Given this list of marker genes ATP9A, MDM2, ERGIC3, PRP4K, MX2, DYNLT2B, PKIG, ICE1, CHP1, VAMP2, RAN, SLC35D3, PTPN23, NUP214, CHP2, COMMD1, UBE2J1, INSIG1, WNK1, KHDRBS1, SIRT6, MLC1, EPM2A, TRIM46, CHRM1, STX18, RBM22, PIK3R2, VPS35, RUFY3, MYBPC3, CHMP3, CPSF6, IFNG, PLA2G3, ERLEC1, MAPK3, PCSK9 (proprotein convertase subtilisin/kexin type 9), NF1, TM9SF4, PPM1A, GRIPAP1, OAZ2, RAB21, SEPTIN8, KIF20B, EIPR1, PRR5L, FLNA, NF2, ANXA2, BVES, GLI3, TMEM97, PTPN1, RAB11A (NCBI Gene Id 8766), RBM4, WWC1, OAZ1, HSP90AA1, ARHGAP1, SHH, TTC21B (tetratricopeptide repeat domain 21B), CRYZL2P-SEC16B, IFI27, RANGAP1, MTMR4, SLC51B, SH3TC2, REEP2, GAS6, ARV1 (NCBI Gene Id 64801), NEAT1, ZDHHC2, EI24, CAMK1, RIOK2, MDFIC, CABP1, RAB29, FERMT1, DAB2, JUP, TRIM58 (NCBI Gene Id 25893), MAP2K1, ANGPT1, MAVS, CDH1, NUMA1, TRIM28, EP300, SIRT7, CRYAB, FRAT1, TPR, PIK3R1, REEP6, SFN, PLN, NUP58, ADIPOQ, UBE2G2, INPP5F, GCC2, PLA2G4E, TXN, EDEM2, UFM1, PSEN1, ARHGAP44, UHMK1, MSN, BORCS5, HHEX, STRIT1, NFKBIA, PRKACA, CDK5, DYNC1H1, NEFH, NDRG4, PRKN, GAS1, BMP4, RAB11FIP3, SCFD1, YOD1, AAAS, EZR, ABCA2, MAP1B, BCAP31, MTMR2, SNX12, LEP, PTPN11, ARHGAP8, REEP5, DNAJC13, SPAG5, ABCA12, HYAL2, UBR5, DDX39A, BRSK2, IER3, EDEM1, DENND10, RAB23, MIR27B, GSK3B, SNX3, PLK3, ECT2, XPO4, PCM1, CDK1, RNF139, RAB11B, RUFY4, CAPN10, SMAD3, YWHAB, OS9, THOC2, MIR185, NUS1, PGAP1, ATP2A1, CTDSPL2, UBAC2, SRC, PARK7, STK11, LRRK2, DERL2, HAP1, SMO, SUFU, LDLRAP1, EFCAB7, MYLK2, PRKCD, HDAC3, SCP2, DHX9, ALKBH5, SUMO1, FRAT2, IWS1, CD81, MAP2, JAK2, PDCD10, DMAP1, RBM10, YIPF5, ASPH, MRLN, RINT1, NEDD4, OAZ3, PRKD1, EMD, NDEL1, SEC16B, ZIC1, MAP2K2, TMEM53, APOD, DERL3, VPS11, CD36 (NCBI Gene Id 948), BARD1, PPP1R12A, EHD1, XBP1, HCLS1 (NCBI Gene Id 3059), MAPK1, CEP290, NRDE2, CRYAA, NCBP2, PKIA, ZPR1, USP7, TENM1, CEP131, AKAP8L, PPP1CC, ACTN2, SLN, TARDBP, SNAPIN, RAPGEF3, EHD2, CDKN2A, IPO5, TBC1D20, BAG3, ZFAND1, FEZ1, TMEM30A, MAPK14, MIR17, PCNT, ANXA2P2, NSUN2, SP100, LAMP1, ARFIP1, FAM76B, ANP32B, TNNC1, AKAP5, IL1B, B3GAT3, TMEM30B, ZC3H12A, SEC24B, XPO1, ATP13A2, SVIP, USE1, PTPN14 (protein tyrosine phosphatase non-receptor type 14), CWH43 (NCBI Gene Id 92961), SORL1 (NCBI Gene Id 6653), NUP153 (NCBI Gene Id 9972), RDX, RIPOR1, SETD2, YWHAE, TGFB1, LCP1, here is a description of the gene set: Human Gene Set: GOBP_REGULATION_OF_INTRACELLULAR_TRANSPORT Any process that modulates the frequency, rate or extent of the directed movement of substances within cells. species: Homo sapiens